Given this list of marker genes Lepr, Mup1, Gck, Mup2 (major urinary protein 2), Pgp, Mup4, Ep300, Kat2a, Erfe, Xpc, Adipoq, Il6, Mtcl2, Mup3, Obp2a, C1qtnf3, Sirt6, Clk2, Mup11 (major urinary protein 11), Mup5, Usp7, Mst1, Cry1, Tcf7l2, Serpina12, Sik1, C1qtnf12, here is a description of the gene set: Any process that stops, prevents, or reduces the frequency, rate or extent of gluconeogenesis. studied in species Mus musculus Mouse Gene Set: GOBP_NEGATIVE_REGULATION_OF_GLUCONEOGENESIS